The following is a description of a gene set: species: Homo sapiens Human Gene Set: chr9p12, and this is the list of marker genes: FKBP4P2, RN7SL763P, FGF7P3, FAM88D, RAB28P1, SDR42E1P1, SNORA70, RN7SL640P, GLIDR, ATP5F1AP8, RPL7AP49, VN2R3P, ZNF658B, RBPJP5, FAM74A1, SPATA31A1, RBM17P1, CNTNAP3, SKP1P3